Given this list of marker genes PCP4L1, KLHDC8A, MYBL2, FHL3 (four and a half LIM domains 3), PYHIN1, GJB2, OSMR, CDR2L, MGLL, EDIL3, PUS7, EML3, FBN2, VEGFD, NEDD4L, CXCL6, TBX4, KIF5C, MPHOSPH6, INCENP, FGF10, KIF18B, HYCC1, EFCAB7, CLMP, PWP2, AEBP1, FST, TIAM1, SLCO2A1, STK38, CDH3, GGT7 (gamma-glutamyltransferase 7), LAYN, COCH, SLC19A1, SIGLEC10, EPS8, PFAS, PKDCC, MNS1, INHBB, PDE8A, NOLC1, SBSPON, PKMYT1, VWA5A (von Willebrand factor A domain containing 5A), STMN2, RAMP3, SGK1, ANXA8L1, SHMT1, TCOF1, WNT2, UBE2C, FAM185A, NPNT, FLT4, ROGDI, TNN, COL6A2, HOXD13, TGFBR3, SGCD, HOXD11, ETV4, TTC7A, DYNAP, SNORD34, PITX1, SERPINB2, CXCR4, IGSF10, FMNL2, STXBP4, DEPDC1, DLST, STEAP1, FGL2, IL1RL1, ASB5, RNF181, HAUS7, PAK1, PUS7L, TEP1, PPBP, NMNAT2, GJB3, ALDH7A1, SFRP2, PRG4, FPGS, ABTB3, TGFBI, COL6A1, DDX23, IQGAP2, GZMH, FUS, DKC1 (dyskerin pseudouridine synthase 1), THBS4, METTL13, FANCA, TROAP, FOSL1, ST3GAL6, FOXF2, MED18, DUSP10, BMAL1, CCNYL1, CLIP4 (NCBI Gene Id 79745), ZNF213, LAMA2, AVPR1A, CASP12, ANGPTL2, HMGN5, TIMELESS, NSRP1, ADAMTS9, RINT1, RAB39B, TMEM45A, PLXNC1, TFAP4, TCF19, DHFR, CHD1L, TNPO2, RRP12, GRB14 (NCBI Gene Id 2888), GSTM5, ARMC6, COL5A3, HROB, CDCA7L, CD44, IGFBP4, PDGFRA, FAM131B, CCBE1, ANK3, ETS2, ADGRG2, here is a description of the gene set: HuR is an RNA-binding protein implicated in a diverse array of pathophysiological processes due to its effects on the posttranscriptional regulation of AU- and U-rich mRNAs. Here we reveal HuR's requirement in embryonic development through its genetic ablation. Obligatory HuR-null embryos exhibited a stage retardation phenotype and failed to survive beyond midgestation. By means of conditional transgenesis, we restricted HuR's mutation in either embryonic or endothelial compartments to demonstrate that embryonic lethality is consequent to defects in extraembryonic placenta. HuR's absence impaired the invagination of allantoic capillaries into the chorionic trophoblast layer and the differentiation of syncytiotrophoblast cells that control the morphogenesis and vascularization of the placental labyrinth and fetal support. HuR-null embryos rescued from these placental defects proceeded to subsequent developmental stages but displayed defects in skeletal ossification, fusions in limb elements, and asplenia. By coupling gene expression measurements, data meta-analysis, and HuR-RNA association assays, we identified transcription and growth factor mRNAs controlled by HuR, primarily at the posttranscriptional level, to guide morphogenesis, specification, and patterning. Collectively, our data demonstrate the dominant role of HuR in organizing gene expression programs guiding placental labyrinth morphogenesis, skeletal specification patterns, and splenic ontogeny. from publication Katsanou V, Milatos S, Yiakouvaki A, Sgantzis N, Kotsoni A, Alexiou M, Harokopos V, Aidinis V, Hemberger M, Kontoyiannis DL (PMID 19307312) Genes down-regulated in MEF cells (embryonic fibroblast) with ELAVL1 knocked out. Human Gene Set: KATSANOU_ELAVL1_TARGETS_DN studied in species Mus musculus